Given this list of marker genes FOSB, ADPGK, TRIM22 (NCBI Gene Id 10346), CRTC3, ZNF337, CCND2, LRRC69, TES, PTGR3, OR6A2, SPCS3, HCP5, DRAM2, ZNF559, ISCU, PGM2L1, N4BP2L2, N4BP2L1, RIN3, S1PR4, CAMK1D, SRPK2, PLEKHA1, PLSCR3, PTPRO, USP3, DOCK10, HLA-F, MACF1, NABP1, TMC8, RPL27, RNASE4, TRIM73, RNF19A, POLK, SERPINB6, CTNS, PIGL, GOLGA8A, KLHDC1, RPL30, CD55, ATF6, GPR183, TMEM63A, ITGB1, TMEM65, RHOB, SLC2A1, CTC1, ARHGAP25, PLAG1, APMAP, MOB3B, CR1, ZNF780A, VPS35, ITIH4, SLC12A6 (solute carrier family 12 member 6), MIR101-1, ZBTB7A, MAN2B1, RPL41, NAAA, TSC22D3, CTNND1, DPH5, KAT2A, MAP3K1, GVINP1, ATXN1, CLIP1, ANKRD6, PARP12, KLF2, PGGHG, ZSCAN9, PTCD2, ZSCAN18, ENTPD1, EFEMP2, TECPR1, LIMD1, IRF2BP2, SMAGP, EML4 (EMAP like 4), ZNF275, SNN, LEMD3 (LEM domain containing 3), SAP30L-AS1 (SAP30L antisense RNA 1 (head to head)), NME3 (NME/NM23 nucleoside diphosphate kinase 3), TMEM154, ANTXR2, TSPYL1, CD46, NOTCH2, JAM3 (NCBI Gene Id 84887), PDE4B, PHYH, TGOLN2 (trans-golgi network protein 2), GPR65, ITPK1, FCGR2C, DNAJC16, ITM2B, NRIP1, STAT1, IQCM, OSGEPL1, RPL35A, FAM89B, TXNIP, CD99L2, CAPS, IL23A, RASAL3, MUC20, BACH1, DGKE, ZNF264, CD48, DUSP22, MYO1F, ARHGAP24, CDC42SE2, PLEKHO2, POU6F1, ADAM28 (ADAM metallopeptidase domain 28), CDKN1A, IL27RA, TRPM2, BTLA, COL4A3, PDGFRB, EIF4A2, C1orf56, AMN1, SERTAD2, ASAH1, ATP13A5, ZNF274, TAF5L, GALNT10, RAB37, IER5, HERPUD2, GALNT1, SH3YL1, IL18BP, SESN1 (NCBI Gene Id 27244), IFNGR1, CLIC3, CCR7, NDFIP1, C14orf28, CSNK1G3, FNDC3A, BCL9L, HSPA6, ZFP36L2, CHD1, LIX1L, CFLAR, NLRP1, ZNF284, ZMIZ1, PLP2, TRIM44 (tripartite motif containing 44), RDX, DUSP1, CCR6, SELENOM, SNX18, ATG14, CRTAP, STARD5, PTPN1, EGR3, KPNA5, PARVG, SKI, BMI1, ZNF419, OAS3, DGKA, LTBP3, TMBIM6, RPL21, ZNF615, LAMP1, RPS6KA5, UST, TMEM59, PLXNC1, RASSF5 (NCBI Gene Id 83593), FCRL4, here is a description of the gene set: Genes down-regulated in comparison of germinal center B cells versus memory B cells. Sorted B cells using flow cytometry. CD19 selected B cells were sorted using flow cytometry. from publication Longo NS, Lugar PL, Yavuz S, Zhang W, Krijger PH, Russ DE, Jima DD, Dave SS, Grammer AC, Lipsky PE (PMID 19023113) species: Homo sapiens Human Gene Set: GSE12366_GC_VS_MEMORY_BCELL_DN